The following is a description of a gene set: studied in species Mus musculus Any process that modulates the frequency, rate or extent of the physical partitioning and separation of a cell into daughter cells. Mouse Gene Set: GOBP_REGULATION_OF_CELL_DIVISION, and this is the list of marker genes: Pdgfc, Prok1, Klhl9, Cspp1, Shh, Uvrag, Hdgf, Birc5, Incenp, Il1b, Mpl, Yme1l1, Pdxp, Lbh, Rxfp3, Kif18b, Zfyve26, Fgf2, Btc, Pdgfa, Nup62, Fsd1, Fgf4, Tex14 (testis expressed gene 14 intercellular bridge forming factor), Bbs4, Svil, Tal1, Gkn1, Wnk1, Cib1, Fgf8 (fibroblast growth factor 8), Setd2, Thoc5, Fgf1, Insc, Rab11fip4, Ncoa3, Ptch1, Tas1r2, Pkp4, Kat14, Drd3, Plk1, Klhl13, Map10, Smyd5, Tas2r124, Cetn2, Exoc7, Sfrp2, Kif20a, Vegfc, Igf2, Ooep, Intu, Cdc6, Pik3c3, Fgfr2, Cdc42, Pdgfb, Pin1, Kif14, Cul3, E2f8, Tgfb1, Efhc1, Evi2b, Garem1, Prkce, Vegfd, Klhl21, Ankrd53, Pax6, Mdk, Calm3, Sox17, Vps4a, Pkn2, Tas2r121, Aurkc, Tle6, Cdc14b, Brca2, Zfyve19, Rab11fip3, Nap1l2, Birc6, Cit, Kif13a, Fgf7, Kif20b, Kat2b, Tas2r102, Atxn10, Git1 (GIT ArfGAP 1), Sh3glb1, Calm2, Fgf5, Rack1, Susd2 (NCBI Gene Id 71733), Cenpv, Chmp4c, Cdca8, Sgf29, Entr1, Kif3b, Pou5f1, Becn1, Ccdc66, Men1, Mrgprb1, Cdc14a, Arf6, Itgb1bp1, Igf1r, Il1a, Tada3, Cdc25b, Pgf, Wnt9b, Ereg, Prc1, Wdr5, Bcl2l1, Aurkb, Gipc1, Map9 (NCBI Gene Id 75994), Rab11a, Pdgfd, Kdf1, Cdk2ap2, Vegfa, Esrrb, Tgfb2, Dr1 (NCBI Gene Id 67362), Tgfb3, Bmyc, Myc, Calm1, Yeats2, Poldip2, Ybx1 (NCBI Gene Id 97156), Ect2, Kat2a, Mllt3, Nkx3-1, Plk3, Ptn, Trp63, Thbs4, Vegfb, Dll1, Cxcr5, Gpr15lg, Myo19, Mbip, Prpf40a, Zbtb18, Nlrp5, Prdm15, Nanog, Htr2b, E2f7, Aspm, Fgf3, Kif23, Ahctf1, Pik3r4, Spast, Fgf6, Sirt2, Cat, Sstr5, Ccp110, Racgap1, Rhoa, Zzz3, Sfn, Chmp3, Tgfa, Blm, Tada2a, Txnip, Apc, Aurka, Drd2, Fgf9